The following is a description of a gene set: Human Gene Set: MORF_LTK Neighborhood of LTK leukocyte tyrosine kinase in the MORF expression compendium species: Homo sapiens Neighborhood of LTK, and this is the list of marker genes: SLC4A3, TM4SF5, MMP25, CRYBA4, SLC30A3, UGT2B15, ECE2, CAMK2B, PRPH, ITIH4, ARC, NTSR2, LBP, PRELID3A, SSTR5, HSD17B3, CMA1, HMGCS2, IGSF9B, RBBP8, NCKIPSD, SUN2, HTR7 (5-hydroxytryptamine receptor 7), SLC5A2, ACKR2, CYP2A6, PICK1, OGG1 (NCBI Gene Id 93577), PTP4A3 (protein tyrosine phosphatase 4A3), SIX3, WDR62, PHF21A, SDC3, HSF4, ENTREP1, SLC30A1, NFRKB, EML3, MYO9B, MOK (NCBI Gene Id 5891), AMFR, IFT140, PML, MT4, LTK, ADAM15, PNMT, GRIK5, N4BP2L2, IGHMBP2, LAIR1, MC2R, CRYAA, ZNF592, NUDT3, RBM8A, NEURL1, GSTM5, PRSS16, ZKSCAN3, IRF2BP1, HAUS5, TUBGCP4, PIGR, FCHO1, GGT5, ARSL, IKBKE (inhibitor of nuclear factor kappa B kinase subunit epsilon), TNFRSF25, LSM12, DAPK2, SLC13A2, HTR4, ARAF, KLHL18, IRF2, SIK3, TRA2A, ITPR2, CYP11A1, CLOCK, RPS6KB2, SMPDL3B, SPEF1, PIK3CB, BCL2, CCKAR, SLC6A9, ZNF710, PAX9, CRHR2, PVT1, DGCR11, PCBP3, CASP2, DDX11, DPYSL4, PIGB, CNTN2, B4GALT3, ADAMTSL2, CRCP, KIFC3, RASSF1, DOK1, FDXR, CARD10, ANKRD12, SLC6A7, DPT, ZNF500, TSPO2, PAIP2B, KAT8, CDK5R1, GPR35, SLC2A1, BAHD1, TBC1D22A, FUT6, GPR17, AQP5, HSPB2, GRIP2 (NCBI Gene Id 80852), GPR161, DTX4, AANAT, SLC12A4, MPP2, MR1, PAX8, SLC24A1, TBX5, FLT1, SLC22A24, TMEM94, SLC16A5, HOXD4, MYL2, TMSB4Y, JAK3, MSX1, TNP1 (transition protein 1), TUB, EXTL3, F7, MTX1